Given this list of marker genes TGFB2, HES1, HEY2, SOX4, LOX, here is a description of the gene set: The progression of the ascending aorta over time, from its initial formation to the mature structure. The ascending aorta is the portion of the aorta in a two-pass circulatory system that lies between the heart and the arch of aorta. In a two-pass circulatory system blood passes twice through the heart to supply the body once. Human Gene Set: GOBP_ASCENDING_AORTA_DEVELOPMENT species: Homo sapiens